The following is a description of a gene set: A change in the morphology or behavior of a hepatic stellate cell resulting from exposure to a cytokine, chemokine, hormone, cellular ligand or soluble factor. Human Gene Set: GOBP_HEPATIC_STELLATE_CELL_ACTIVATION species: Homo sapiens, and this is the list of marker genes: LEP, GCLC, ACTA2, DDR2, MYB, CYGB, RPS6KA1, AKAP12, GCLM